Given this list of marker genes Osr1, Six4, Myc, Smad4 (SMAD family member 4), Pax2 (NCBI Gene Id 207129), Shh (sonic hedgehog), Wnt4, Wt1, Six1, Stat1, Tcf21, Pkd2, Bmp7, here is a description of the gene set: species: Mus musculus The biological process whose specific outcome is the progression of a metanephric mesenchyme from an initial condition to its mature state. This process begins with the formation of metanephric mesenchyme and ends with the mature structure. Metanephric mesenchyme is the tissue made up of loosely connected mesenchymal cells in the metanephros. Mouse Gene Set: GOBP_METANEPHRIC_MESENCHYME_DEVELOPMENT